Given this list of marker genes Rhob, here is a description of the gene set: electronically inferred by orthology from the curated human pathway part of: RHO GTPase Effectors species: Mus musculus Reactome Pathway: RHO GTPases Activate ROCKs This event has been computationally inferred from an event that has been demonstrated in another species.<p>The inference is based on the homology mapping from PANTHER. Briefly, reactions for which all involved PhysicalEntities (in input, output and catalyst) have a mapped orthologue/paralogue (for complexes at least 75% of components must have a mapping) are inferred to the other species.